Given this list of marker genes Serpine1, Serpinb6c, Serpinb6a, Serpinb6e, Klk8, Serpinb6d, Plat, Plau (NCBI Gene Id 18792), Serpina5, Casp1, Serpinb6b, here is a description of the gene set: studied in species Mus musculus Mouse Gene Set: GOCC_PROTEASE_INHIBITOR_COMPLEX A heterodimeric protein complex that contains a protease inhibitor and a protease; formation of the complex inhibits protease activity.